Given this list of marker genes RBPJ, SOX17, SOX18, OVOL2, NOTCH1, PROX1, here is a description of the gene set: Human Gene Set: GOBP_ENDOCARDIUM_MORPHOGENESIS studied in species Homo sapiens The process in which the anatomical structure of the endocardium is generated and organized. The endocardium is an anatomical structure comprised of an endothelium and an extracellular matrix that forms the innermost layer of tissue of the heart, and lines the heart chambers.